The following is a description of a gene set: species: Homo sapiens Human Gene Set: REACTOME_TOLL_LIKE_RECEPTOR_9_TLR9_CASCADE Toll Like Receptor 9 (TLR9) Cascade, and this is the list of marker genes: ATF2, IKBKG, BTRC, RIPK2, NKIRAS1, TIFA, DUSP6, IKBIP, CUL1, FOS (NCBI Gene Id 2353), S100B, RELA, JUN, NLRX1, ALPK1, IRAK4, TRAF6, DUSP4, NFKB2, PIK3R4, TAB3, CHUK, MEF2C, IRF7, MEF2A, NOD2, UBE2N, IRAK2, DUSP3, MYD88, MAP2K3, N4BP1, RPS6KA5, MAPK3, AGER, PPP2CA, TRAF2, MAPKAPK3, PPP2R1A, HMGB1, TNIP2, SAA1, UBE2V1, TLR7, LY96, MAP2K6, MAPK10, MAPK11, TAB2, PIK3C3, MAP2K1, MAP2K4, RPS27A, RPS6KA3 (ribosomal protein S6 kinase A3), IKBKB, ELK1, TLR4, NOD1, UBC, MAP2K7, MAP3K1, MAPK1, USP14, RPS6KA2, NLRC5, MAPK8, APP, CASP8, PELI2, SLC15A4, RPS6KA1, S100A12 (NCBI Gene Id 6283), TICAM2, TICAM1, PPP2R5D, MAPK9, RBSN, PELI3, NFKBIA, NFKBIB, TAB1, TASL, PELI1, DUSP7 (dual specificity phosphatase 7), TLR9, TP53, MAPK7, ECSIT, MAPK14 (mitogen-activated protein kinase 14), LRRC14 (leucine rich repeat containing 14), MAP3K8, USP18, CREB1 (cAMP responsive element binding protein 1), MAP3K7, UBA52, ATF1, NKIRAS2, IRAK1, CD14, UBB, IRF5 (interferon regulatory factor 5), EEA1, FBXW11, PPP2CB, MAPKAPK2 (MAPK activated protein kinase 2), SKP1, NFKB1, VRK3, PPP2R1B